Given this list of marker genes Grip2, Adra1b, Htr2b, Serpinf2, Trpm4, Itgb1, P2rx4, Avpr1b, Arhgap42, Gch1, Hmgcr, Kcna5, Dusp5, Sirt1, Fgb, Cx3cl1, Nos1, Adra1a, Pdgfb, Mgll, F2rl1, P2rx1, Fgg, Irag1, Itga1, Agt, Hif1a, Agtr1a, Apln, Foxc2, Mmp2, Mtnr1b, Wnt9b, Ednra, Rap1gds1, Adm, Adora1, Kcnj8, Npy1r, Rock2 (NCBI Gene Id 77848), Ece1, Gpx1, Mas1, Itga9, Avpr1a, Adcy6, Atp1a2, Agtr2, Abcc9, Akt1, Tgfbr3, Cyp2j5, Dock5, Fga, Faah, Abl1, Uts2, Drd5, Grk2, Tbxa2r, Drd1, Adrb3, Add3, Egfr, Chrm3, Gja1, Sod2, Acta2, Htr2a, Cps1, Avp, Edn3, Gper1, Atp2b1, Adrb1, Svep1, Klk1b1, G6pdx, Nppa, Htr1d, Agtr1b, Pde5a, Nts, Chga, Npr1 (natriuretic peptide receptor 1), Prkg1, Lep, Bloc1s6, Hrh2, Htr1a, Uts2r, Avpr2, Adra1d, Calca, Adrb2, Dock4, Gucy1a1, Klf2, Ptgs2, Htr2c, Ptgs1, Cd38, Ptprm, F2r, Sod3, Adra2c, Ednrb, Ins1, Adora2a, Nppb, Ace, Tacr1, Pla2g6, Npr3, Itga4, Cacna1c, Gclm, Abcc1, Smad6, Kcnmb1, Mkks, Stub1, Gja5, Hrh1, Rock1, Ahr, Ext2, Shc1, Adra2a (NCBI Gene Id 11551), Plod3, Scpep1, Ins2, Plekha7, Kdr, Rbfox2, Esr2, Adra2b, Itgb1bp1, Rgs2, Bmpr2, Kcnma1, Adora2b, Bdkrb2, Oxtr, Cbs, Nos3, Vstm4, Cacna1g, Vegfa (vascular endothelial growth factor A), Ptger3, Htr1b, Map2k1, Asic2, Crp, Scnn1b, Tbxas1, Slc8a1, Snta1, Casr, Foxc1, Rhoa, Comp, Apoe, Cftr, Dbh, Atg5, Tnf, Ptk2, P2ry2, Smtnl1, Ext1, Uts2b, Adcyap1, Edn1, Bbs2, Nppc (natriuretic peptide type C), Per2, Ppard, Ucn, Kat2b, Alox5, Htr7, Gclc, Manf, Cysltr1, Slc6a4, Icam1, Cav1, Edn2, Smpd3, Wdr35, Kng1, Kng2, P2ry1 (NCBI Gene Id 18441), Mrgprd, Sod1 (superoxide dismutase 1, soluble), Zdhhc21, here is a description of the gene set: studied in species Mus musculus Mouse Gene Set: GOBP_REGULATION_OF_TUBE_SIZE Ensuring that a tube is of the correct length and diameter. Tube size must be maintained not only during tube formation, but also throughout development and in some physiological processes.